Given this list of marker genes GTF2H4, UBC, USP7, ERCC8, POLR2F, POLR2H, ERCC3, CUL4A, COPS8, MNAT1, POLR2E, TCEA1, UBA52, GTF2H5, POLR2K, POLR2A, AQR, ZNF830, ERCC2, XAB2, CCNH, POLR2J, COPS7A, ISY1 (NCBI Gene Id 57461), COPS7B, GTF2H3, ERCC6, COPS2, GTF2H1, POLR2D, POLR2C, UVSSA, PPIE, DDB1, POLR2I, COPS4, RPS27A, GPS1, RBX1, GTF2H2, CDK7, POLR2L, COPS3, POLR2G (NCBI Gene Id 5436), PRPF19, COPS6, CUL4B, UBB, POLR2B, XPA (NCBI Gene Id 7507), COPS5, here is a description of the gene set: Human Gene Set: REACTOME_FORMATION_OF_TC_NER_PRE_INCISION_COMPLEX Formation of TC-NER Pre-Incision Complex studied in species Homo sapiens